Given this list of marker genes Lif, Cxcl13, Ptk2, Crkl, Ccl21a, Acer2, Fermt1, Cd3e, Cyp1b1, Ccl5, Adam9, Wnk1, Ccl21e, Lyn, Dpp4, Nexmif, Lpxn, Ccl21f, Cd24a, Epha2, Hrg, Epha8, Rac3, Skap1, Ptpn11, Nckap1l, Efna1, Ret, Tesc, Syk, Ccl21d, Foxc2, Ccl21b, Tescl, Itgb3, Swap70, Jam3, Fermt3, Plau, Tgfb2, Cib1, Ift74, Piezo1, Ada, Muc1, Ptpn6, Serpine1, Crk, Itgb1bp1, Snai2, Podxl, P2ry12, here is a description of the gene set: Mouse Gene Set: GOBP_REGULATION_OF_CELL_ADHESION_MEDIATED_BY_INTEGRIN Any process that modulates the frequency, rate, or extent of cell adhesion mediated by integrin. species: Mus musculus